Given this list of marker genes S1pr2, Ptprs, Robo4, Dll1, Mir874, Cldn1, Arhgef26, Prok2, Rap1a, Rdx, Flvcr2, Jag1, Fzd2, Magi1, Smad4, Bmp6, Bmpr2, Acvr1, Pdpn, Heg1, Kdm6b, Cnmd, Apold1, Akap11, Vcl, Tnf, Gdf2, Ren1, Ppp1r16b, Bmp4, Tnfrsf1a, Tgfbr1, Hapln2, Col18a1, Hey2, Hoxb5, Hpse, F11r, Cldn3, Pde4d, Acvr2b, Cul7, Rock2, Icam1, F2rl1, Clic4, Ednra, Lipa, Edn1 (endothelin 1), Nrg1, Dsg2, Tjp1, Vegfa, Barx1, Tnmd, Amotl2, Tie1, Zeb1, Rock1, Sox17, Tmem100, Sox18, Marveld2 (MARVEL (membrane-associating) domain containing 2), Fstl1, Rapgef1, Pde2a, Cxcr4, Add1, Plod3, Tjp3, Hoxa13, Fzd1, Ezr, Msn, Id1, Acvrl1, Proc, Vhl, Foxj2 (forkhead box J2), Atoh8, Stc1, Rapgef3, Xdh (xanthine dehydrogenase), Zdhhc21, Cdh5, Myadm, S1pr1, Rap1b, Notch4 (NCBI Gene Id 224712), Vezf1, Rbpj, Afdn, Mesp1, Hey1, Met (met proto-oncogene), Ccm2, Gpx1, Ednrb, Prox1, Nr2f2, Bmpr1a, Rapgef2, Fasn, Etv2, Ift88, Agt (angiotensinogen), Rap2c, Pbrm1, Plcb1, Dmd, Ctnnb1, Abcb1b, Btg1, Ndp, Cldn5, Foxp3, Fzd4, S1pr3, Kdr, Dicer1, Ubiad1, Pecam1, Myd88, Ceacam1, Tjp2, Ikbkb, Notch1, Il1b, here is a description of the gene set: The process in which a mesodermal, bone marrow or neural crest cell acquires specialized features of an endothelial cell, a thin flattened cell. A layer of such cells lines the inside surfaces of body cavities, blood vessels, and lymph vessels, making up the endothelium. Mouse Gene Set: GOBP_ENDOTHELIAL_CELL_DIFFERENTIATION species: Mus musculus